The following is a description of a gene set: Mouse Gene Set: GOBP_EYE_PHOTORECEPTOR_CELL_DIFFERENTIATION The process in which a relatively unspecialized cell acquires the specialized features of a photoreceptor cell, as found in the eye, the primary visual organ of most organisms. studied in species Mus musculus, and this is the list of marker genes: Bbs10, Thy1, Dscam, Nr2e3, Hcn1, Poc5, Vegfa, Ahi1, Rpgrip1l, Stat3, Miat, Gnat1, Sdk2, Gngt1, Samd11, Nrl, Alms1, Agtpbp1, Prom1, Sox9, Sox8, Dzank1 (double zinc ribbon and ankyrin repeat domains 1), Fscn2, Cabp4, Cntf, Mir124a-2, Mfrp, Cnga3, Casz1, Bbs4, Rpgrip1, Mir182 (NCBI Gene Id 387177), Crb1, Bhlhe23, Pdgfb, Naglu, Mir124a-1, Rorb, Dio3, Ush1c, Ihh (Indian hedgehog), Slc4a7, Ptn, Samd7, Prdm1, Ppp2r3a, Thrb, Vax2os, Gabrr2, Cfh, Trpm1, Mir96, Notch1, Pax6, Th, Mir183, Ndp, Gnat2, Rp1, Rdh13, Pde6c, Olfm3, Tulp1, Cep290, Crb2 (crumbs family member 2), Rpgr, Prkci (NCBI Gene Id 99620), Ttc8, Rom1, Otx2, Ntrk2